Given this list of marker genes KRT81, STC1, KANK2, LAMTOR3, RPRD2, GIMAP4, CARF, GPR17 (NCBI Gene Id 91962), PLXNA2, HSPD1, BCL6, MKX, MBNL2, LAP3, MIR137HG, NFATC3, DUSP1, RSRC2, GSTA5, PLXNC1 (NCBI Gene Id 121370), PIKFYVE, ITGA8, SIX4, CCT3, PTHLH, ST13, FOXD2, NR4A3, FAP, KNTC1, GPRASP2, SMYD1, EPHA2, TYR, GDPD3, ABCD1, SCG2, KRT85, JMJD6, DMRT1, HIPK1, ADAMTS9, ATP6V1A, ATL2, CACHD1, DAZ2, BNC2, GOT1L1, SHISA6, SHANK1, ISYNA1, DAZL, HOXB8, CCDC126, CHD1, POU4F3, ATG13, SERPINH1 (serpin family H member 1), MAP2, CNTF, ZBTB20, CBX3, PAK3, BCL9 (NCBI Gene Id 607), CMTM4, ACOT7, PIM1 (NCBI Gene Id 82453), C10orf53, PCDH10, TRIB1, PIP5K1A, IL2, ZC3H11A, ARHGAP6, PRKAG1, SREBF2, SRP54, BCAP31, PPT2, CCM2, CBY1, CREM, TLK1, NR2F1, ABCC5 (ATP binding cassette subfamily C member 5), SEM1, GRIK1 (glutamate ionotropic receptor kainate type subunit 1), NOB1, BPIFB1, DMRTA1, PPP2R2C, PURG, RTN1, WNT8B, SIDT1, EIF5, LRRC8B, FHL1, EHD1, MYOCD, DNAJA1, PNKD, HIVEP2, LINC01106, GLRA3, TRERF1, IGFBP5, GAD1, GATA3, GPBP1, NT5C3A (5'-nucleotidase, cytosolic IIIA), CHST8, TRDN, TNFRSF19, ELAVL4, TPM2, ADCY8, GREB1, CHORDC1, SETD2, UBE2E2, CRISP1, ADAMTS2, NAA50, NECAP1, HARBI1, LINC00114, STIM2, TSHZ3, RORB, MAPK14, PDE6D, IER5L, MORF4L2, KRIT1, RPH3AL, ZNF777, WDR12, ACTN2, TNPO3, CADM1, MARCKSL1, IRF2BPL, NFATC4, MAGI3, FNDC9, AAMP, H2AZ1, TREX1, PLEKHB1, PACSIN3, JAM3, NKPD1, IQUB, MARCHF10, UMODL1, LENEP, TFAP2D, U2AF1L4, BMPR2, TSSK3, GSN, PHF6, SLC24A4, DBI, NFAM1, PLXDC2, NEK6, EVA1C, ANKRD28, OTX2, ASAH2, HIKESHI, XPNPEP3, RNF220, YWHAG (NCBI Gene Id 96443), HSP90AB1, ALKBH6, ADCY6, HSPB1, KCNQ1, MOBP, FKBP4, TGIF1, PRDM12, VASH1, CSRNP3, LHFPL2, IZUMO1, DMD, NOL4, SPO11, RAB6B, RBPMS, NNAT, LINC00173, LARP4, AGPAT1, CISH, TMEM243, NRXN3, ZFX, SOCS5, PTGIS, RBFOX1, E2F3, ILDR2 (immunoglobulin like domain containing receptor 2), RFX4, CLDN2, OSR2, OTP, DENND1B, GRM1, ZBTB9, GIGYF1, NR2C2, ANKRD22, PAK1IP1, STX12, JUN, FOS, TAB2, DMRTB1, EOMES, RIMS2, DNAJB1, PPP2R5C, ASCL4, HSPA8, PIP5K1P1, TMEM131L, TPI1P2 (NCBI Gene Id 392986), MRPS6, RASGRP2, UNC79 (NCBI Gene Id 57578), FOXB1, SMAD1, HNRNPA2B1, HCN4, HTN1, OPRD1, CYLD, NUFIP2, GAD2, EGR3, TMEM107, HSPB8, MAPK1IP1L (mitogen-activated protein kinase 1 interacting protein 1 like), ZNF280C, FLNC, WRN, CCNG1, CACNA2D2, FSTL3, PNMA1, ABHD3, ID4, ELOVL5, HS6ST3, TSACC (NCBI Gene Id 128229), SCUBE3, CCDC65, C12orf50, VTCN1, CHML, NETO2, SOCS2, DNAJB5, ATP1B2, HSPH1, FBXW4, RNF5, TXLNGY, SGF29 (SAGA complex associated factor 29), ZNF212, LUZP1, here is a description of the gene set: studied in species Homo sapiens Genes having at least one occurrence of the motif AGAANRTTCN in the regions spanning 4 kb centered on their transcription starting sites. This matches the HSF1 transcription factor binding site V$HSF1_01 (v7.4 TRANSFAC). Human Gene Set: HSF1_01